Given this list of marker genes KRT16, LMX1B, IL11RA, DVL1, ROR2, KRT6A (keratin 6A), LRP4, FZD2, SOST (NCBI Gene Id 8149), DVL3, NXN, WNT5A, KRT6B, KRT17, TFAP2A, TP63, here is a description of the gene set: Fingernail dysplasia studied in species Homo sapiens Human Gene Set: HP_FINGERNAIL_DYSPLASIA An abnormality of the development of the fingernails.